The following is a description of a gene set: Abnormality of canine Human Gene Set: HP_ABNORMALITY_OF_CANINE An abnormality of canine tooth. studied in species Homo sapiens, and this is the list of marker genes: KDM1A, APC, MSX1, FGF3, WNT10A, AXIN2, EDARADD (NCBI Gene Id 128178), PAX9, IRF6, DDX59, FGFR1, LRP6, CHSY1, TGFA, EDA, SUMO1, WNT10B